Given this list of marker genes C11orf71, SLC41A2, TOMM40, ZNF418, TRIP11, here is a description of the gene set: from publication Chen Y, Wang X (PMID 31504780) species: Homo sapiens Human Gene Set: MIR662 Genes predicted to be targets of miRBase v22 microRNA hsa-miR-662 in miRDB v6.0 with MirTarget v4 prediction scores > 80 (high confidence targets).